The following is a description of a gene set: Mouse Gene Set: GOMF_INTERLEUKIN_1_RECEPTOR_ACTIVITY Combining with interleukin-1 to initiate a change in cell activity. Interleukin-1 is produced mainly by activated macrophages and is involved in the inflammatory response. studied in species Mus musculus, and this is the list of marker genes: Il1r1, Il18rap, Il1rapl2 (NCBI Gene Id 60367), Il1rl2, Il1r2, Il1rl1, Il1rap